The following is a description of a gene set: Human Gene Set: HP_ARACHNODACTYLY Arachnodactyly Abnormally long and slender fingers (spider fingers). species: Homo sapiens, and this is the list of marker genes: ZEB2, ASXL3 (ASXL transcriptional regulator 3), NUP107, BMP4, DLG4, CYP26B1, OTUD6B, LOX, ATP2B1, THSD4, FGFR3, YRDC, SMARCE1, FGFR2, BRD4, TGFBR1, RECQL, FOXE3, TBX1, POLR3H, SEC24C, MRPS22, KANSL1, ZSWIM7, PIGG, SLC2A10, SUFU, MYLK, H3-3B, B4GALT7, PLOD1 (procollagen-lysine,2-oxoglutarate 5-dioxygenase 1), SIN3A, UFD1, SCARF2, AEBP1 (NCBI Gene Id 165), EFEMP1, SMS, MFAP5, RNU4-2, OSGEP, CHRNG, HIRA, LETM1, CBS, DPAGT1, SKI, HEY2, HNRNPH1, UNC80, PYCR2, SON, SATB2, ZDHHC9, RREB1, SMAD2, SMAD3, IPO8, PRDM5, PSMC3IP, MED12, FBN2, SPIDR, XYLT2, PEPD, TGFB2, PAPPA2, ELN, UBE3B, MAT2A, ABL1, FARSA, COMT, VPS13B, MAPK1 (NCBI Gene Id 5594), CPLX1, NARS1, CIC, ZNF469, BMP1, NKAP, ACTG2, POR, NPR2, FBXO11, NELFA, FBN1, HERC1, COL2A1, ASPH, ARVCF, SOX6, BCR (BCR activator of RhoGEF and GTPase), NSD2, PTCH1, DSE, EFEMP2, MTM1, FSHR, BNC1, TGFBR2, CRKL, HNRNPH2, TGFB3, UPF3B (UPF3B regulator of nonsense mediated mRNA decay), PQBP1, GP1BB, FLNA, CTBP1, ACTA2, AMER1, LAGE3, PIEZO2, FBLN5, CHST14, CTSC, STUB1, SH2B1, NR5A1, CNTN1, SMAD4, MSH4, B3GALT6, C1R, BGN, MYH11, PRKG1 (NCBI Gene Id 5592), BMP15, PHF8, COL11A1, PTCH2, NPR3, ALG14, JMJD1C, NALCN